The following is a description of a gene set: from publication Radaeva S, Jaruga B, Hong F, Kim WH, Fan S, Cai H, Strom S, Liu Y, El-Assal O, Gao B (PMID 11910354) Genes down-regulated in primary hepatocytes and Hep3B (hepatocyte) cells in response to IFNA. BACKGROUND & AIMS: Interferon (IFN)-alpha therapy is currently the primary choice for viral hepatitis and a promising treatment for hepatocellular carcinoma (HCC). Primary mouse and rat hepatocytes respond poorly to IFN-alpha stimulation. Thus, it is very important to examine the IFN-alpha signal pathway in primary human hepatocytes. METHODS: The IFN-alpha-activated signals and genes in primary human hepatocytes and hepatoma cells were examined by Western blotting and microarray analyses. RESULTS: Primary human hepatocytes respond very well to IFN-alpha stimulation as shown by activation of multiple signal transducer and activator of transcription factor (STAT) 1, 2, 3, 5, and multiple genes. The differential response to IFN-alpha stimulation in primary human and mouse hepatocytes may be caused by expression of predominant functional IFN-alpha receptor 2c (IFNAR2c) in primary human hepatocytes vs. expression of predominant inhibitory IFNAR2a in mouse hepatocytes. Microarray analyses of primary human hepatocytes show that IFN-alpha up-regulates about genes by over 2-fold and down-regulates about genes by 50%. The up-regulated genes include a variety of antiviral and tumor suppressors/proapoptotic genes. The down-regulated genes include c-myc and c-Met, the hepatocyte growth factor (HGF) receptor. Down-regulation of c-Met is caused by IFN-alpha suppression of the c-Met promoter through down-regulation of Sp1 binding and results in attenuation of HGF-induced signals and cell proliferation. CONCLUSIONS: IFN-alpha directly targets human hepatocytes, followed by activation of multiple STATs and regulation of a wide variety of genes, which may contribute to the antiviral and antitumor activities of IFN-alpha in human liver. Human Gene Set: RADAEVA_RESPONSE_TO_IFNA1_DN species: Homo sapiens, and this is the list of marker genes: PLEC, PDGFA, AP1G2 (adaptor related protein complex 1 subunit gamma 2), GLP1R, KMT2A, MYCL, MET, FOS, CEP170B (centrosomal protein 170B), KIT